The following is a description of a gene set: studied in species Homo sapiens Human Gene Set: GOBP_POSITIVE_REGULATION_OF_EPITHELIAL_CELL_DIFFERENTIATION Any process that activates or increases the frequency, rate or extent of epithelial cell differentiation., and this is the list of marker genes: LHX1, PLAAT4, GDNF, ACVRL1, MACROH2A1, CTNNB1, CYP27B1, ATOH8, KDF1, BMP7, AHI1, CD24, SERPINE1, ALOX15B, MACROH2A2, OVOL2, PAX8, PROM1, IL13, NKX6-1, MIR199B, PKP1, MIR150, MIR181B1, FOXJ1, NUMA1, FOXC1, LIF, BMP2 (NCBI Gene Id 650), MESP1, IL20, MIR204, VEZF1, MIR21, TP73, LEF1, TMEM100, SULT2B1, ETV2, NKX2-2, PTCH2, ZBED2, GDF2, BAD, PAX6, MIR34A, TRIM16, ATOH1, SFRP4, VDR, SOX9, FGF2, NOTCH1, BTG1, PTCH1, MIR125B1, BMP6, BMP4, RFX3, PRKCH, FOXN1, MED1, NME2, MIR181A2, NCOA3, SPRR5, MIR99B, MIR200C, IPO7, ETV4, ZEB2, WNT10B, PAX2, SFN, RPTOR